The following is a description of a gene set: species: Homo sapiens Pathway Definition from KEGG: PROK1/2 -> PROKR1/2 -> GNAI -> ERK PROK-PRKR-Gi-ERK signaling pathway. Pathway ID: N00879. Pathway type: Reference. Pathway class: nt06361 Hypogonadotropic hypogonadism. Human Gene Set: KEGG_MEDICUS_REFERENCE_PROK_PRKR_GI_ERK_SIGNALING_PATHWAY, and this is the list of marker genes: PROKR1, PROKR2, MAPK1, PROK1, PROK2, MAPK3, GNAI3, GNAI2, GNAI1